Given this list of marker genes UBE2C, MELK, LIG1, UCK2, CDCA3, CDKN2C (NCBI Gene Id 654235), H2AX, ANP32E, KPNA2, PTGR1, MCM6, SLBP, CCNB1, RBBP4, SMARCA5, HAUS3, CKS1B, CDKN3, HJURP, NCAPH, PREP, CKAP5, DNMT1, KIFC1, ACTN4, CENPL, CDC45, EZH2, HMGB2, LGALS1 (galectin 1), TUBB4B, MCM3, MCM10, RRM1, DCK, H2AZ2, CHEK1, PRDX4, RAMP1, CCNB2, RAD51, RRM2, LMNB1, NEK2, HMGB1, TUBB, CDCA5, SMC2, CBX1, DTL, MCM7, MCM2, CDK1, TUBA1A, CCNA2, MKI67 (NCBI Gene Id 4288), RAG1, H2AC8, CDC20, SMC4, CDCA7, SLC29A1, SLC16A1, PCNA, NUSAP1, PRIM1, TXN, IGLL5, TOP2A, XRCC6, PCK2, DLGAP5, PRC1, CDKN1A, TTK, GSN, HNRNPA3, IQGAP3, RAD54L, E2F8, CENPA, TMPO, SMARCA4, ENPEP (NCBI Gene Id 2028), HMGN2 (NCBI Gene Id 94860), STMN1, TUBA1B, HMGB3, HNRNPAB, MTHFD2, here is a description of the gene set: Human Gene Set: MORI_IMMATURE_B_LYMPHOCYTE_DN from publication Mori S, Rempel RE, Chang JT, Yao G, Lagoo AS, Potti A, Bild A, Nevins JR (PMID 18922927) Down-regulated genes in the B lymphocyte developmental signature based on expression profiling of lymphomas from the Emu-myc transgenic mice: the immature B stage. studied in species Mus musculus The Emu-myc transgenic mouse has provided a valuable model for the study of B-cell lymphoma. Making use of gene expression analysis and, in particular, expression signatures of cell signaling pathway activation, we now show that several forms of B lymphoma can be identified in the Emu-myc mice associated with time of tumor onset. Furthermore, one form of Emu-myc tumor with pre-B character is shown to resemble human Burkitt lymphoma, whereas others exhibit more differentiated B-cell characteristics and show similarity with human diffuse large B-cell lymphoma in the pattern of gene expression, as well as oncogenic pathway activation. Importantly, we show that signatures of oncogenic pathway activity provide further dissection of the spectrum of diffuse large B-cell lymphoma, identifying a subset of patients who have very poor prognosis and could benefit from more aggressive or novel therapeutic strategies. Taken together, these studies provide insight into the complexity of the oncogenic process and a novel strategy for dissecting the heterogeneity of B lymphoma.